The following is a description of a gene set: Mouse Gene Set: GOMF_SEQUENCE_SPECIFIC_DNA_BINDING Binding to DNA of a specific nucleotide composition, e.g. GC-rich DNA binding, or with a specific sequence motif or type of DNA e.g. promotor binding or rDNA binding. species: Mus musculus, and this is the list of marker genes: Barhl1 (NCBI Gene Id 54422), Dnmt1, Bcl2, Tbx10, Nkrf, Figla, Snai3, Hlf, Smad4, Pax4, Onecut3, Gsc, Erg, H2az1, Nsd1, Atf1-ps, Ascl3, Zfp345, Mbd3, Zfp459 (zinc finger protein 459), Prmt1, Runx1 (NCBI Gene Id 12394, runt related transcription factor 1), Zfp14, Zfp607b, Zfp977, Dmrtb1, Zbtb43, Prdm5, Zfp454, Helt, Zbtb7b, Zfp429, Camta1, Med8, Zfp980, Ascl5, Erf, Myc, Gli2, Nkx6-1 (NK6 homeobox 1), Tbx15, Hdgf, Hoxb7, Taf2 (NCBI Gene Id 319944), Zbtb18, Zfp740 (zinc finger protein 740), Zfp952, Zfp563, Gm614, Obox2, Med1, Hdx, Rbpj, Pou2af2, Rbmx, Hoxc11, Cbx4 (NCBI Gene Id 12418), Elf2, Hoxd12, Mlxipl, Foxo6, Zfp239, Hoxc13, Obox5, Cdx1, Eno1b, Cenpc1, Zfp383, Purb, Zfp768, Zfp236, Pgbd1, Klf12, Zfp955a, Rad21, Tgif2lx2, Prox2, Foxo1, Zfp251, Ankrd23, H3f3b, Foxn4, Zfp853, Vax1, Drgx, Erhrt-ps, Zfp771, Trp73, Zbtb22, Pdx1, Ehf, Zfp871, Nkx2-6, Hivep2, Zfp747l1, Pbx1, Zfp418, Esrra, Hoxa10, Myt1l, Jmjd8, Zfp874b, Zfp131, Junb, Tbpl1, Irx1, Zscan4-ps1, Mcm5, Nfib, Zfp612, Skil, Lhx4, Olig2, Hoxc6 (NCBI Gene Id 15425), Etv2, Stat3, Ep300, Orc5, Jph2, E4f1, Zbtb25, Zfp442, Hic1, Nme1, Dlx1, Bcl11b, Cbx3 (NCBI Gene Id 12417), Sp5, Atxn3, Hes7, Lhx1, Ahrr, Dmrta1, Zscan26, Zeb2, Gm4767, Nr4a1, Nrl, Zfp354a, Zfp616, Zbtb7a, Maf1, Zscan10, Pou6f1, Zfp652 (zinc finger protein 652), Grwd1, Zkscan8, Foxa3 (forkhead box A3), Zfp58, Foxb1, Zfp773, Zfp821 (NCBI Gene Id 75871), Plagl2, Camta2 (NCBI Gene Id 93727), Isx, Otx1, Rnf10, Kdm2a (NCBI Gene Id 71431), Thra, Bmal2, Rela (v-rel reticuloendotheliosis viral oncogene homolog A (avian)), Stat4, Zbtb38, Klf1, Zfp750, Rhox12, Zfp92, Rps3, Egr1, AW146154, Nlrp3, Klf14, Creb1, Irf5, Fendrr, Zfp799, Bcl6b, Zfp868, Uty, Hoxb6, Zfp994, Olig1, Zfp811, Esr2, Mycn, Myod1, Bbx, Pou3f1, Men1, E2f5 (NCBI Gene Id 99821), Sohlh2, Rpa1, Hoxb2, Calcoco1, Hand2, Atoh1, Foxj2, Stk16, Rxrg (retinoid X receptor gamma), Stn1, Spic, Zbtb46, Hsf4, Plag1, Kcnh2, Nfe2l1, Alx1, Irx4, Nfya, Zbtb16, Irx6, Rex2, Zic4, Tcf7, Atf3, Zfp644, Pou3f4, Hes6, Zfp12, Lbx2, Zfp451, Hesx1, Tcfl5, Zbed4, Nr2c1, Lhx6, Rbl1, Zfp493, Zcwpw1, Rbl2, Dnmt3a, Rara, Zfp626, Gata5, Gm7072, Safb2, Grhl2, Zfp775, Zfp367, Tcf15, Sub1, Hes1, Chtop, Zfp169, Kdm6a, Rb1, Osr1, Alx3 (aristaless-like homeobox 3), Rfx4, Prrx2, Zfp82, Gm35315, Zfp873, Ncoa1, Zfp697, Hoxa5, Zfp282, Thap11, Sox14, Notch1, Snapc1, Neurog1, Glis3, Snai2, Prdm2, Zfp512b, Kcnip3, Hoxc9 (NCBI Gene Id 15427), Klf15, Mlh3, Meis1, Mcm10, Zfp658, Olig3, Ubtf, Cc2d1a, Tbx20, Sox2, Cebpa, Zfp566, Zfp420, Zbtb12, Smarcb1, Neurod4, Blm, Obox8, Zfp202, Ell2, Yy1, Bhlhe22, Purg, Zfp846, Foxl1, Jmjd4, Mtor, Muc1, Nr2f6, Zscan4e, Zfp668, Zfp72, Pou1f1, Ell3, Rel, Scx, Nfatc4, Rfx7, Tgif2, Dhx33, Mir208b, Gm14391, Zfp74, Wiz, Foxq1, Hmgb1, Ferd3l, Vsx1, Orc2, Emx2 (empty spiracles homeobox 2), Smad2, Pbx2, Sox3, Acd, Cdc5lrt9, Rrn3, Taf9, Zfp870, Gatad1, Zeb1, Chd7, Med12, Zfp551, Zfp677, Zfp719, Zfp941, Zfp184, Foxl2, Gm19965, Nrip1, Mybbp1a, Mafb (NCBI Gene Id 16658), Mir214, Aebp1, Zfp976, Zscan4c, Lmx1a, Zfp947, Macroh2a2, Mef2b, Hnrnpk, Zkscan7, Nr1h2, Wt1, Cdc6, Smad5 (SMAD family member 5), Atf1, Dmrta2, Dmtf1l, Tcf7l1, 2610008E11Rik, Ttc39aos1, Meox1, Zbtb9, Rhox6, Hdac6, Zfp119a, Zfp874a, Cdc45, Barhl2, Nfe2, Zfp696, Smg1, Nabp2, Barx1, Suv39h2, Rbmxl1, Zfp1006, Srf, Zfp647, Tfap4, Atf5, Atmin, Tsnax, AI987944, Zbtb32, Zfp639, Orc1, Tiparp, Zfp707, Zglp1, Zbtb5, Csrnp2, Zfp975, Gm32687, Klf2, Smarca4, Maz, Zbtb24, Mtf2, Zfp81, Irx5, Mnt, Scrt1, Zbtb34, Pou2f1, Fli1, Zfp641, Pparg, Zfp397, Wrn, Prdm9, Msc, Zfp39, Tbx6, Klf8, Brd7, Dach2, Zfp449, Shox2, Zfp946, Stat5a, Rhox13, Ccnt1, Hdac2, Tbl1x, Zfp322a, Osr2, Polrmt, Nkx2-4, Cdc5lrt10, Ehmt2, Mxd3, Nr1h3, Phox2b, Ybx1, Gm10033, Zfp689, Gata4, Nr1d1, Ptbp1 (polypyrimidine tract binding protein 1), Cebpe, Pou2f3, Gata6, Hoxd11, Nfatc1, Zfp141, Pou2f2, Elk4, Zfp932, Tcf12, Dlx2, Ppara, Zfp2, Dlx4, Msh3, Nr1h4, Zfp787, Elf4, Zfp248, Gbx1, Thrap3, Mafg, Cebpg, Zfp217 (zinc finger protein 217), Ikzf5, Per1, Zfp958, Zbtb48, Zfp935, Nr5a2, Gzf1, Hmga2, Zfp623, Zic2, Foxj3, Ascl4, Ikzf3, Nr3c2 (nuclear receptor subfamily 3, group C, member 2), Meis2, Nfx1, Foxn2, Elf3, Zfp648, Zscan20, Hsfy2, Snai1, Cebpd, Foxp4, Zkscan14, Batf (NCBI Gene Id 54359), Hoxc10, Bnc2, Foxe3, Zc3h8, Evx2, Hoxc12, Lrwd1, Zfp931, Xrcc6, Zfp146, BC024063, Rslcan18, Sp3, Ctcfl, Zbtb37, Pknox1, Mafa (MAF bZIP transcription factor A), Vezf1, Pou3f3, Hmx1, Polr2a (NCBI Gene Id 20020), Gli1, Zfp950, Cxxc5 (CXXC finger 5), Zfhx2, Ubtfl1, Ogg1, Neurod2, Ski, Ovol1, Zfp101, Yap1, Foxf1, Zfp867, Lhx3 (NCBI Gene Id 16871), Sp1, Foxo3, Zfp568, Pax2, Zfp819, Zbtb2, Hsf3, Uhrf1, Kdm6b, En2, Tgif2lx1, Patz1, Nfe2l2, Chd3, Phox2a, Pbx4, Smc3, Zfp341, Repin1, Stat6, Pou6f2, T, Zfp516, Maf, Zfp30, Atf4, Rhox10, Arx (aristaless related homeobox), AU041133, Ten1, Pou4f1, Rere, Egr2, Ctcf, Sirt3, Hdac1 (histone deacetylase 1), Sox15, Nr1d2, Nr6a1, Hnrnpab, Lin28b, Mzf1, Xpa, Zfp189, Hoxa7, Nfic, Fos, Atf7, Cxxc4, Zfp296, Sall2 (spalt like transcription factor 2), Bach1, Zbtb11, Hoxb9, Cphx1 (NCBI Gene Id 97922), Tbx2, Crebrf, Gm14296, Gfi1b (growth factor independent 1B), Cdc5l, Nkx1-2 (NCBI Gene Id 20231), Nr4a3, Per2, Smad1, Gabpa, Mecom, Tef, Zfp148, Obox1, Zfp54, Pbx3, Sox18, Zfp354b (NCBI Gene Id 27274), Nfatc3, Smad9, Zfp423, Noto, Hes2, Hbp1, Pola1, Zbtb14, Mta3, Zfp324, Rpa2, Alx4, Dlx6, Zfp964, Tsn, Zkscan16, Atoh8, Aire, Gm14325, Rorb, Nr1i2, Gmnn, Nkx3-2 (NK3 homeobox 2), Gtf2a1 (general transcription factor II A, 1), Zfp711 (NCBI Gene Id 69243), Foxc2, Onecut2, Zfp266, Nkx2-5, Pot1a, Foxp1, Hoxd13, Foxr1, Hoxb4, Tinf2, Elk3, Otp, Csrnp3, Zscan4-ps3 (NCBI Gene Id 632758), Atf6b, Myf5 (myogenic factor 5), Crebbp, Zfp655 (NCBI Gene Id 72611), Nkx1-1, Actn4, Crx, Zkscan5, Zfp174, Dbp, Dhx9, Hmx2, Lmnb1, Zfp110, Hoxb3, Ash2l, Klf10, Bhlha15, Zfp536, Zscan22, Irf9, Bhlhe23, Vdr, Yy2, Gbx2, Bmyc, Foxd3, Sp6, Trim24, Nacc1, Sox1, Lbx1, Fosb, Smg7, Plagl1 (NCBI Gene Id 70469), Arid4a (NCBI Gene Id 320602), Tbx5, Zfp882, Klf3, Mybl1, Tet3, Bahd1, Foxr2, Sox12, Fev, Zfp90, Zfp872, Ebf3, Tlx2, Wbp2, Ptf1a, Pax8, Pax6, Zfp113, Zfp438, Per3, Gm14434, Ncoa3, Nfxl1, Gm14401, Rbbp4, Tcf24, Insm2, Rsl1, Sltm, Zfp69, Emx1, Ercc6, Esrrb, Foxd4, Fezf1, Gmeb2, Etv5, Twist2, Hnrnpu, Zfp13, Fosl2, Zfp7, Batf2, Hoxa13, Sox21, Zscan4-ps2 (NCBI Gene Id 665913), Terf2, Zfp524, Zfp990, Nfil3, Hnf4a, Prmt5, Smarca2, Tbx22, Zfp628, Prrx1, Foxn3, Bptf, Peg3, Hsf2, Barx2, Foxk1, Duxbl1, Zbtb10, Tbl1xr1, Zscan4d, Tert, Ddn, Zfp456, Ncoa2, Bhlha9, Dmtf1, Myb, Zfp523, Kcnh8, Pitx1, Esrrg, Zfp810, Ccar1, Arnt2, Zfp683, Gabpb1, Mrtfa, Foxi2, Egr3, Prdm1, Hey2, Abl1, Irf8, Pax1, Rag1, Tug1, Top2a, Zfp513, Vsx2, Zfp758, Zfp746, Arid4b, Nfatc2, Ar, Sox11, Six2, Mafk, Atoh7, Pou5f2, Zfp433, Foxd2, Etv6, Runx3, Meis3, Hsf5, Zfp704, Sars1, Tead1, Rax, Zfp597, Zbtb26, Rora, Kmt2b, Insm1, Tfap2b, Zfp869, Foxj1, Mbd2, Hoxa3, Arap1, Nlrc5, Zbtb33, Gm3604, Eomes, Neurog3, Chchd2, Zfp180 (zinc finger protein 180), Sp2, Rreb1 (ras responsive element binding protein 1), Obox3, Zfp354c, Heyl, Hoxa1, Zfp472 (NCBI Gene Id 224691), Zfp382, Six4, Hnf4g, Spib, Zfp444, Nkx6-2, Rxra, Mxd4, Platr25, Hnrnpd, Suv39h1, AI854703, Nfkb1, Zfp68, Zkscan17, Uncx, Pif1, Orc3, Sp8, Gcm2, Zfp599, Zfp105, Tead2, Nhlh1, Zfp37, Nhlh2, Tbx21, Zkscan3, Suz12, Foxg1, Zfp352 (zinc finger protein 352), Stox1, Zfp998, Rbpjl, Thrb, Bcor, Ikzf1, Zfp784 (NCBI Gene Id 654801), Irf7, Preb, Zfp28, Zfp280d, Zfp212, Tal2, Zfp329, Sim1, Cdc5lrt5, Bhlhe41, Skor1, Zbtb21, Gtf3c5, Arid5a, Zscan4b, Dlx3, Zfp160, Nfix, Nfyb, Tcf23, Hoxa4, Zscan4f (zinc finger and SCAN domain containing 4F), Zfp667, Zfat, E2f4, Zfp988, Zscan2 (NCBI Gene Id 22691), Zfp280b, Zfp989, Zbtb6, Tfdp2 (NCBI Gene Id 319491), Sall1, Mycl, Zfp865, Pgr, Zfp954, Scrt2, Lhx8, Nkx6-3, Rest, Ppard, Nfyc, Tead3, Mta2, Zfhx4, Zfp582, Zfp369, Gm5141, Zic5, Taf7, Mef2a, Sp7, Dlx5, Dmrtc2, Telo2, Hoxa11, Zfp276, Hhex, Hand1, Twist1, Ovol2, Stat2, Zfp3, Cebpb, Mtf1, Smad3, Zfp560, Clock, Taf1, Pou5f1, Zfp992, Prdm15, Brf1, Hnf1b, Zfp747, Kdm5b, Zfp955b, Zfp583, Gm14444, Adnp, St18, Zfp979, Spdef, Gfi1, Zfp316, Gcm1, Ets2, Mesp1, Myrf, Zkscan6, Kdm2b, Dmbx1, Safb, Sohlh1, Crem, Zfp984 (zinc finger protein 984), Hmbox1, Upf3a, Hopx, Atf6, Sox4 (NCBI Gene Id 20677), Zfp982, Zfp507, Nr2f1, Zfp24, Zfp213, Meox2, Tfam, Hif1a, 4930522L14Rik, Ascl1, Zfp820, Vax2, Gmeb1, Zfp985, Klf11, Zscan5b, B020011L13Rik, Zfp809, Hif3a, Zfp273, Zfp120, Sox7, Zfp87, Hoxd3, Irf2, Hes5, Gm14403, 5730507C01Rik, Mnx1, Nr2c2, Zfp9, Prop1, Gsc2, Isl2, Zic3, Foxh1, Six1, Grhl1, Ahr, Brf2, Zfp277, Nr1i3, Zfp128, Taf1c, Rfx5, Gata3, Hoxd8, Nfkb2, Gm14418, Pias1, Bach2, Tlx3 (NCBI Gene Id 27140), Mta1, Zfp708, Zbtb20, Gm4924, Mlxip, Zfp85, Kat7, Eno1, Zfp983, Tlr9, Tcf20, Foxa1, Sp140, Zscan12, Kdm1a, Nfkbiz, Ddit3, Mbd3l1, Chd2, Rad50, Elf5, Klf13, Ets1 (E26 avian leukemia oncogene 1, 5' domain), Zbed6, Foxi3, Mxi1, Mkx, Tbx4, Neurog2, Hdac5, Zfp637, Nr2f2, Gatad2b, Mlx, Zfp691, Dmrt3, Zfp281, Tet1, Sox30, Zfp617, Tgif1, Foxk2, Alkbh2, Gm14322, Kmt2d, Arid5b, 2010315B03Rik (NCBI Gene Id 72071), Tbr1, Hoxb8, Ppargc1a, Rfx1, Sox17, Hivep1, E2f8, Mga, Hmga1, Zfp579, Creb3 (cAMP responsive element binding protein 3), Hnrnpl, Nr5a1, Foxn1, Irf6, Nfat5, Sox6, Nanog, Satb1, Bsx, Zfp729b (NCBI Gene Id 380856), Hinfp, Ybx3, Hey1, Foxf2, Tfap2d, Csrnp1, Nacc2, Hoxb13, E2f7, Kat2b, Casz1, Mcm2, Gm15446, Jdp2, Zfp334, Zfp764l1, Basp1, Mbd1, Etv3, Ciart, Foxp2, Bnc1, Prox1, Sfpq, Zfp41, Max, Bcl11a, Etv4, Creb3l1, Mypop, Ciita, Eef1d, Zfp53, Zfp84, Xrcc5, Neurod6, Tfap2e, Hoxd1, Cxxc1, Stox2, Hmga1b, Fubp1, Msx1, Ago1, Rfxank, Usf1, Smyd3, Zfp1, Sox5, Trp63, Rfc1, Tbp, Stat5b, Cux1, Hcfc1, Gm45871, Setx, Gtf2ird1, Elf1, Zfp558, H3f3a, Zfp286, Cdc5lrt4, Gata2, Zfp764, Zfp949, Rhox11, Pitx3, Ncor1 (NCBI Gene Id 320690), Msh2, Zfp65, Foxa2 (NCBI Gene Id 15376), Hnf1a, Hoxb1, Taf1b, Pax3, Terf1, Zkscan2, Macroh2a1, Zbtb41, Zfp366, Npas4, Foxc1, Zfp995, Zfp410, Zfp263, Duxf3, Blvra, Cic, Cux2, Tbx19, Mtpn, Zbtb1, Egr4, Zfp966, Zfp937, Cdk9, Tcf4, En1, Zbtb4, Lhx5, Gm14443, Gtf2b, Pcbp1, Ctc1, Zfp358, Gli3, Notch4, Mbd3l2, Zfp930, Klf16, E2f2, Myf6, Carf, Hsf1, Zfp182, Esx1, Prdm4, Batf3, Mmp12, Prdm16, Hnrnpa2b1, Zfp362, 2810021J22Rik, Zbtb17, Tfe3, Gm6871, Pot1b, Rorc, Ovol3, Zfp219 (zinc finger protein 219), Cpsf4, Mitf, Gm14399, Mxd1, Hmx3, Ebf2, Lhx2, Zfp790, Tfdp1, Rbak, Klf5, Zgrf1, Gm12258, Klf7, Zfp712, Foxm1, Lyl1, Dmrtc1b, Myef2 (myelin basic protein expression factor 2, repressor), Zfp710, Ddx11, Tead4, Msgn1, Zim1, Mynn, Nkx2-9, Zfp934, Evx1, Nr4a2, Zfp971, Erh, Zfp692, Pou4f3, Zfx (NCBI Gene Id 22766), Satb2, Trp53bp1, Mycs, Cdx4, Upf2 (NCBI Gene Id 326622), Cdc5lrt6, Cc2d1b, Zfp973, Nfe2l3, Npm1, Zfp825, Dhx36, Zfp960, Zfp672, Pknox2, Pasd1, A430033K04Rik, Xrn2, Mesp2, Creb5, Creb3l3 (cAMP responsive element binding protein 3-like 3), Snapc4, Spi1, Zfp970, Zfp956, Etv1, Tcf3 (NCBI Gene Id 21423), Six5, Cdc5lrt8, Cdk5rap2 (CDK5 regulatory subunit associated protein 2), Zfp735, Nr0b1, Sox10, Nr3c1, Dmrtc1a, Elk1, Mef2c, Trp53, Sox8, Trps1, Tfap2c, Rfx8, Myog, Zfp772, Zfp777, Zfp940, Bhlhe40, Usf3, Irx3, Usp3, Terf2ip, Zfp119b, Glis1, Upf1, Zfp715, Mybl2, Lonp1, Zfp408, Ubp1, Xbp1, Gabpb2, Rfx6, Duxf4, Creb3l4, Zfp157, Hoxd10, Ncl (NCBI Gene Id 319677), Hoxd9, Zfp944, Obox7, Zfp961, Hoxc8, Lmx1b, Bcl6, Zfp143, Foxs1, Otx2, Klf4, Zfhx3, Nr1h5, Runx2, Mbnl2, Hoxa6, Rad23b, Tbx1, Notch2, Fbxl19, Sry, Zfp991, Smg6, Tfcp2l1, Brca1, Spz1, Neurod1, Ebf1, Nsd2, Tcf21, Tfeb, Foxi1, Myt1 (myelin transcription factor 1), Rarg, Zkscan1, Zkscan4, Tbx3, Klf6, Cbfb, Hoxb5, Rfx2, Zfp398 (zinc finger protein 398), Esr1, Mterf1b, Jund, Hoxa9, Brd4 (NCBI Gene Id 57261), Rfxap, Nfia, Npas3, Irx2, Zscan21, Zfp963, Maff, Ell, Foxo4, Zfp59, Srebf1, Sox13, Sp9 (trans-acting transcription factor 9), Fosl1, Ebf4, Stat1, Zbtb45, Onecut1, Pax5, Srebf2, Pax9, Zfp987, Glis2, Cdc5lrt1, Lrrfip1, Pitx2, Zfp943, Orc4, Thap1, Kdm5a, Bmal1, Six3, Myrfl, Zfp951, Sim2, Tfcp2, Sox9, Foxp3 (NCBI Gene Id 20371), Prdm14, Dpf1, Dach1, Zfp46, Zfp260, Gm17655, Tcf7l2, Dmrt1, Top1, Pax7, Grhl3, Msx3, Zfp879, Rag2, Zscan25, Mixl1, Rxrb, Chchd2-ps, Zfp395, Hlx, Pou4f2, Epas1, Tbx18, Zfp575, Nr2e1, Zfp1004, Bend3, Gm2381, Npas1, Zik1, Zfa-ps, Hoxd4, Zfp175, Zfp850, Cry2, Npas2, Creb3l2, Litaf, Nr2e3, Zfp287, Lhx9, Ruvbl2, Zfp942, E2f1, Prdm11, Zbtb7c, Zfp455, Zfp933, Tal1, Rbbp5, Zfp664, Foxb2, Fezf2, Foxe1, Ascl2, Zfp580, Hivep3, Nkx3-1, Zfp965, Zfp981, Nrf1, Isl1, Kmt2a, Hoxc4, Klf9, Mecp2, Zfp446, Zgpat, Zbtb39, Msx2, Zhx3, Tnf, Mef2d, Zfp317, Cry1, Zfp763 (zinc finger protein 763), Zic1, Hnrnpa1, Tardbp, Zfp97, Gsx2, Lef1, Sp4, Ikzf4, E2f6, Zfp1010, Zfp866, Dmrt2, Carm1, Zbtb8a, Obox6, Sirt1, Hdac4, Rfx3 (regulatory factor X, 3 (influences HLA class II expression)), Zfp78, Foxd1, Foxl3, Gata1, Nkx2-3, Irf3, Drap1, Prdx5, Zfp426, Atf2, Irf4, Nkx2-2, Smad6, Arnt, Zfp663, Nkx2-1, Nobox, Tfap2a, Ncor2, Usf2, Zfp42, Zfp534, Ikzf2, Zfp280c, Ago2, Mael, Zfp709, Pou3f2, Ezh2, Tfec, Hoxa2, App, Zfp335, Snapc3, Smg5, Hoxc5, Klf17, E2f3, Hes3, Skor2, Zscan29 (NCBI Gene Id 99334), Pura, Zfp1007, Gsx1, Cdc5lrt7, Deaf1 (NCBI Gene Id 54006), Six6, Hmgb2, Relb, Erbb4, Zfp384, Jun, Mterf3, Dmrtc1c1, Zfp607a, Apex1, Zfp275, Zfp386, Cdx2, Wdr77, Rarb, Zbtb49, Irf1